The following is a description of a gene set: Human Gene Set: GOBP_NAD_BIOSYNTHETIC_PROCESS The chemical reactions and pathways resulting in the formation of nicotinamide adenine dinucleotide (NAD+), a coenzyme that interconverts with its reduced form, NADH, in many redox and catabolic reactions. NAD+ is derived from various sources including vitamin B3. species: Homo sapiens, and this is the list of marker genes: IDO2, QPRT, NMNAT3, NMNAT2, NAMPT, KYNU, HAAO, KMO, NAPRT, NMRK2, AFMID, NMNAT1, IDO1 (NCBI Gene Id 3620), NMRK1, NADSYN1, ACMSD, ASPDH